Given this list of marker genes DUSP4, DUSP6, DUSP8, FGFR1, FPR1, FGF2, EGF, TAB1, ADORA2B, RGS4, KCNH2, DUSP2, GADD45G, RGS3, C5AR1, ADRA2A, here is a description of the gene set: studied in species Homo sapiens Genes in the cancer module 173. Human Gene Set: MODULE_173